Given this list of marker genes Pkia, Prkar2a, Prkar1a, Prkar2b, Lpar1, Pde3a, Prkar1b, here is a description of the gene set: Mouse Gene Set: GOBP_NEGATIVE_REGULATION_OF_CAMP_PKA_SIGNAL_TRANSDUCTION Any process that stops, prevents or reduces the frequency, rate or extent of cAMP/PKA signal transduction. studied in species Mus musculus